The following is a description of a gene set: The aggregation, arrangement and bonding together of a set of components to form a postsynaptic membrane, a specialized area of membrane facing the presynaptic membrane on the tip of the nerve ending and separated from it by a minute cleft (the synaptic cleft). Human Gene Set: GOBP_POSTSYNAPTIC_MEMBRANE_ASSEMBLY studied in species Homo sapiens, and this is the list of marker genes: NLGN2, NLGN1, NRXN1, NRXN2, CDH2, LRP4, EPHB2, NLGN3